Given this list of marker genes ETV2, MIR1-1, CER1, PUS7, TP63, MIXL1, RPS6KA6 (NCBI Gene Id 27330), here is a description of the gene set: Human Gene Set: GOBP_REGULATION_OF_MESODERM_DEVELOPMENT Any process that modulates the frequency, rate or extent of mesoderm development. species: Homo sapiens